The following is a description of a gene set: species: Homo sapiens Human Gene Set: HP_APLASIA_HYPOPLASIA_OF_THE_VAGINA Aplasia/Hypoplasia of the vagina Aplasia or developmental hypoplasia of the vagina., and this is the list of marker genes: NR0B1, TTC8, IFT74, BBS1, VAMP7, BBIP1, MKKS, BBS12, MAP3K1, IFT27, GATA4, B3GLCT, SOX9, CYB5A, WNT4 (NCBI Gene Id 54361), SDCCAG8, DHX37, TRIM32 (NCBI Gene Id 3971), ARL6, NR5A1, BBS10 (Bardet-Biedl syndrome 10), NPHP1, CEP19, MKS1, IFT172, PPP2R1A, CYP11B1, LZTFL1, PAX3, BBS4 (Bardet-Biedl syndrome 4), BBS9, IRF6 (NCBI Gene Id 7452), BBS2, SRY, WWOX, CEP290, GLI3, CFAP418, SCLT1, CYP17A1, BBS7, BBS5 (Bardet-Biedl syndrome 5), SCAPER, WDPCP, GATA3, WT1, ZFPM2